Given this list of marker genes Fbxo4, Mkx, Ncor1, Bnip1, Ccdc51 (NCBI Gene Id 66658), Mettl21a, Toe1, Map2k2, Tmem119, Itgb1, Nr2f6, Sgk1, Tiam1, Polr3g, Zfp526, Uck2, Lrrc75a, Afg3l2, Gm1976, Frmd8os, Nemp2, 9930012K11Rik, Asb6, Usp9x, Plod3, Dynlt1-ps1, Tfb2m, Furin, A130014A01Rik, Gabpb1, Mid1ip1, Pgp, Gm15471, Ddt, 6330409D20Rik, Wdr3, Hspa4, Sugct (succinyl-CoA glutarate-CoA transferase), Pacrg, Emc4, Tubb2b, Zfp811, Cnst, E4f1, Copg1, Prss36, Mgat1, Mpv17l2, Prmt9, Igsf8, Snord2, Stra6l, Fv1, Uck1, Katnb1, Vmp1, Stard6, Scrt1, Casp16, Irf1, Rsl24d1, Kank2, Tcea2, Arap1, H6pd (NCBI Gene Id 14379), Cdk13, Naa20, Slc35d1, Ntaq1, Ebag9, E230029C05Rik, Parp16, Brd1, Jmjd6, Havcr2, Ptpmt1, Adprm, Nr2c2, C5ar2, Mir8109, Thap6, Sun2, Gm12500, Lactb2, Mir9-2hg, Efcab2, Cinp, Bmpr1a, Nop16, Ankrd40, Slc38a1, Pcid2, Ppp2r5d, Rock2, Pex5, Nck1, Cenatac, Adamtsl5, Cenpb, Malsu1, Gm15704, Cisd2 (NCBI Gene Id 99732), mt-Nd6, Hmgxb3, Reep5, Pik3cd, Dhdh, Gm18407, Amacr, Wsb2, Ndufs6 (NADH:ubiquinone oxidoreductase core subunit S6), Irak2, Proser1, C1qbp, Tram2, Rbm47, Slc29a2, Tifa, 2610203C22Rik, Gm15510, Rin3, Zbtb7a, Shkbp1, Ilrun, Tmem240, Tnip1 (NCBI Gene Id 57783), Tfcp2, Hdhd5, Rps27l, Pard6a, Traf3, Gm16299, Zfp1006, Rab3il1, Nfe2, Por, Mrpl3, Trak2, Rnft1, Trir, Dgkz, 3110031N09Rik, 2900041M22Rik, Gtf2ird2, Rnf13, Nipa2, Nhlrc3, Gm25703, Ankle1, Zfp444, Acaca, Tgif1, Mbd6, Hlx, Dsn1, Cfap126, Gstm1, Gm35986, Klf4, Spen, Lrmda, Irak4, Vmac, Fam43a, Sipa1l3, Slbp, Hsd17b10, Rnd2, Ndufaf1, Ung, Plekhb1, Mogs, Sgms1, Rps6ka1, Atp6v1g1 (NCBI Gene Id 98834), Gpn3, Trip4, Stn1, Mettl23, Mdfic, Acot8, Map3k8, Baz2a, Rapgef2, A930005H10Rik, Gm16120, 4930595D18Rik, Tmem42, G6pc3, Trpv2 (transient receptor potential cation channel, subfamily V, member 2), Mblac2, Snapc2, Ak4 (NCBI Gene Id 51874), Btf3, Fsd1l, Gga1, Ip6k2, Cdnf, Cd72 (CD72 antigen), Rfc4 (NCBI Gene Id 224052), E2f2, Ddx21, Kpnb1, Gid4, Nr4a3, Pafah1b1, 4930447M23Rik, Ppt1, Trpm8, Bub1, Tektip1 (NCBI Gene Id 432479), Ifitm6, Abhd12, Zc3h14, Rgs18, Elmo2, Hsd17b2, Cltc, Pwwp2b, D130017N08Rik, Rxrb, Cox7a1, Gm4479, Etfa, Dpp9, Mexis, Atp5mj, Slc44a1, 0610043K17Rik, Eif4e, Hrh3, Mcph1, 1700066B17Rik, Tars3, Izumo1, Fntb, Cspp1, Gtpbp4, Gm21992, Dnaja2, Gm14275, Prkn, Hsd17b14, Nhp2, Stk4, Whrn, Ido2, Churc1, Bms1, Frmd4a, Miip, Pparg, Alkbh8, Rptor, Zbtb6, Unc50, Lmna, Orm3, Myo9b, Gm15246, Esrra, Dhrs11, Pdcd4, Lrp11, Znhit1, Nlrp3, Gm27003, Tgfbrap1, Mkrn1, Rbm27, Zdhhc5, 4931422A03Rik, Coq9, Prkar2a, Hsp90aa1, Ipo4, Nfat5, Dyrk2, Diaph3, Mettl2, Opa3, BC048644, Ier3ip1, Vpreb1a, Fam98c, Garin5a, Fbxl13, Nostrin, Arhgap31, Gm16253, Uspl1, Epn1, Aff1, Tdrd3, Cic (NCBI Gene Id 71722), Dbi, St6gal1, Gas7, St8sia5, Pes1, Ptgr2, Pcm1, Cyp2w1, Sdha, Dnaja1, Nln, Uqcrq, Prmt7, 9930014A18Rik, Cd37, Hk3, Ube2q2, Ncor2, Cdk20, Tor3a (torsin family 3, member A), Psma7, Smurf1, Trmt2a, Akt1, Klk1b16, Fblim1, Med1, Eeig1, Sft2d2, Dcaf6, D330041H03Rik, Spag9, Zbtb7b, Gata3, Mib2, Galt, Arid4a, Stk10, Ninj1, Tnip2, Wdr87-ps, Mtag2 (NCBI Gene Id 50994), Syncrip, Epo, Gm43838, 1810019N24Rik, Ulk1, Psd4, Galnt9, Ece1, Cers6, Gm15417, Sec11a, Rcan3, Camta2, Mplkip, 2310061I04Rik, Lilra6, Asf1b, Eno1, Gm23969, Cks1b, Malat1, Src, Ccl9, Degs1, Stk36, Setd5, Hoxa7, Atp5f1b, Slc25a29, Atxn2, mt-Tt, Impact, Ndufb6, Gm29707, Sigmar1, Brms1, Mast3, C3, Upp2, Hsd3b7, Rrm2b, Cytip, Stx16, Josd1, Slc39a7, Gbp11, Patz1 (POZ (BTB) and AT hook containing zinc finger 1), Lrrc42, Hhat, Psma3, Ap5b1, Mtarc2, Arih1, Gm12274, Suds3, Ndufaf4, Hemk1, Fam193a, Zfp101, Hnrnpr, Gm25296, Nfkb2, 4933430I17Rik, Apobec3, Pebp1, Tufm, Eif2s3x, Tomm20, Bach2os, 4930547M16Rik, Rpl12, Junos, Ndufb4, Aldh7a1, Lrsam1, Fdxr, Myo1c, Lipn, Steap3, Tmem65, Ifi207, Rb1cc1, Vamp8, Wdfy3, Smyd3, Hexb, Tradd, Styxl1, Nmbr, Arfrp1, Guf1, Nlrp1b, Kansl1, Mir9-2, Ndufa1, Afg1l, Clec4a1, Pde8a, Gm15133, Ppp2r3d, Tagln2, Gm5617, Atp13a4, Klhdc10, Klhl28, Cul3, Tbc1d9b, Cd28, Tjp2, Txnrd2, Lgals8, Usp3, Exd1, Pld1, Vsir, Gbp10, Ampd2, Pank3, Chp1, Inca1, Pole4, Steap1, Mta2, Mdm4, Phf5a, Tmub1, Dctn5, Mitf, Soat2, Gm16191 (predicted gene 16191), Kif17, Gnaq, Ccdc66, Dph5, Ndel1, Armt1, St3gal3, Gm26654, Eeig2 (EEIG family member 2), Uap1, Mrm1, Stom, Stradb, Homez, Trf, Tma7, Parp10, Vim, Slc7a7, Tmem186, Gm28047, Fasn, Gatad2a, Abca8b (NCBI Gene Id 27404), Cetn4, Ckap5, Tagap, Esyt2, Eif4a2, Cdk5rap1, Tprn, Katnal2, Myef2l, Zfp523, Dnajc4, Kcnab1, Zfyve1, Lrrc8c, Smarcd2, U2surp, Npc1, 4930515B02Rik, E230016M11Rik, Pus7l, Mgst2, Fam3c, Rasl11a, Tbc1d20, Tdrd5, Junb, Hectd2, Slc66a3, Usp46, Vegfb, Phtf2 (NCBI Gene Id 97226), Gmfg, Ccdc88b, Wdfy2, 2210022D18Rik, Fosl2, Oas3, 2310068J16Rik, Zbed4, Eif2b2, Slc11a1, AU019990, Tbc1d25 (NCBI Gene Id 52090), Natd1, Mir8105, Ints6, Zmym2, Relt, Gm20186, Dpy19l1, Ddost, Tmod1, Ranbp1, Atg101, Peli1, Adsl, Alad, Gm16576, Pmm2, Nmnat3, Prrg4, Vegfa, Ggnbp2, Wasf1, Capzb, Neat1, Eef1b2, D430040D24Rik, Dph2, Cnnm3, Gm10244, Ptges, Eif2a, Med23, Ehd1, Bccip, Sdf2l1 (stromal cell-derived factor 2-like 1), Fam90a1b, Pola1, Plscr1, Prkag1, Ptbp1, 2210011K15Rik, Kcnk2, Gm16548, Dmxl2 (NCBI Gene Id 76881), Parvg, 1500002C15Rik, Gm12367, Gpcpd1, Uchl3, Gna13, Ppdpf, Cacnb1, Pex13, mt-Tp, Polr3d, Orai1, Zbtb20, H4c16, Tmem87b, Hcst, Abca1, Sh3bp2, Utp14b, Plk2, Fbxo6, Cd320, Lsm8 (LSM8 homolog, U6 small nuclear RNA associated), Mrpl2, 1700025A08Rik, Uros, Tmco4, Tsc22d1, Ddx50, Ivns1abp, Mcoln1, Erf, A230056P14Rik, Mif4gd, Dmxl1 (Dmx-like 1), Gm10459, Msl2, Ndufa12, 4930563E22Rik, Zhx2, Gm29257, Wdsub1, Luzp1, Pum3, Syngr1, Arid4b, Rasl11b, Mis18a, Ppp1r18, Sema4d, Traf1, Tbc1d4, Mospd3, 2310022B05Rik (NCBI Gene Id 69551), Slc11a2, Rack1, Kremen1, Rnf145, Myo1g (myosin IG), Tmem268, Gpr35, Daam1, Ywhag, Alkbh3os1 (alkB homolog 3, opposite strand 1), Ecsit, A930018P22Rik, Uqcc6, mt-Tv (NCBI Gene Id 17745), Mrps33, Rrm2, Mad1l1, Gm10766, Asb15, Fdft1, Mrps18c, Ppfia3, Pex11a, Foxj2, Isy1, Cox5b, Bbs12, Nudt18, Hdhd3, Fut8, D5Ertd579e (NCBI Gene Id 77811), Prkch, Srp68, Tcerg1, AI597479, Smagp, Bloc1s1, Gm26084, Myadml2, Zfp770, Snai3, Dmwd, Tas1r1, Stx11 (NCBI Gene Id 74732), Mx2, Tpcn2, Rps6kc1, Hes6, Sco1, Nol9, Ilvbl, Ubxn2a (NCBI Gene Id 217379), Snrk, Rad21, Dhrs3, Il12b, Zfpm1, Ptges2 (prostaglandin E synthase 2), Gm6899, Tmem229b, Pyroxd1, Tmem135, Phldb1, Dis3, Rps5, Dip2c, Wdr83, Il16, Lhx1 (LIM homeobox protein 1), 4732491K20Rik, Slc25a10, Gsap, Tnfaip2, Myo6, Fkbp15, Eml2, Osgin1, Ctu1, Eva1c, Gm13431, Bnip3, Agpat4, Znrf1, Hspa1l, Armc10, Cycs, 6720482G16Rik, Gm7285, Coq7, 1700047G03Rik, Yif1b, Commd5, Icam1, F10, Trp53inp2, Ttc7b, Ado, Mir207, Mrpl1, Mad2l2, Sumo3, Vav3, Zmym5, Hycc2, 3110009E18Rik, Rgs19, Cep70, Hnrnpu, Chic2, Usp37, 4930432B10Rik, Zfp706, Ndufc1, H2az1, Lbp, Pkdcc, Tbpl1, Ogdh, Pank1, Smad7, Spata1, Hmgb1, Gm4430, Gm4890, Gm16433, Sirpa, Gm15567, Syt7, 1600020E01Rik, Slc49a4, Aco2, Gm11205, Coq10b, Hpdl, Rnf25, Cd164, Pcgf5, Med28, Nr3c1, Fkbp5, Cdk4, Eny2, Gm6410, Pold4, Sgsm1, Gm15952 (predicted gene 15952), Tceanc, Rhoc, Dbp, Cfap43, Phf13, Nudcd1, Wipf1, Gm16104, Meis3, Naip5, Ska3, Numbl, Cst3, H2-DMa, Plxnd1, Zdhhc7, Wdr4, Mphosph9, Rad23b, Il23a, Hsph1, Mycbp (MYC binding protein), 2310005A03Rik, Psmb10, Nadk, Acsl3, Lexis1, Fos, 2610005L07Rik, Cebpd, Gpr84, Mir5615-1, Emp3, 1500026H17Rik, Gm16279, Agpat5, Ncbp2, Gnb2, Aim2, Ttc21a, Nudcd2, Atf7, B930094E09Rik, n-R5s88, Armc9, Usp48, Ccdc57, Wnt9b, 4930599N24Rik, Maml1, Megf9, Fbxo30, Atrip, Uqcrc1 (ubiquinol-cytochrome c reductase core protein 1), Ippk, Card9, Tpra1, 2300009A05Rik, Jun, Gm5577, Matk, Prkag2, Efcab9, Ttc39a, Hnrnpc, Ogt, Sik3, Apoo, Fndc3a, Zc3hc1, Mpc1, Acox1, Faah, 4930503L19Rik, Il6, Ap5s1, Ikbke, Mon1b, Shc1, Pfkp, Cyth1, Ggnbp1, Map3k4, Repin1, Limk2, Cntd1, mt-Te, 6430710C18Rik, H1f4, Gdf9, Mpc2, Ifrd1, mt-Rnr2, Ciapin1, 4930477E14Rik, Adcy7, Desi1, 2310044K18Rik, Ndufa3, Hk1os, Tnk2, Dnttip2, Gatad1, Stk11, Sdhaf2, Shb, Gm15473, Cisd3, Nucb1, Gm20492, Gm9530, Npas2, Fcrl1, Sestd1, Gm4799, Elovl6, Gins1, Scd2, Wdr55, Gt(ROSA)26Sor, Tnfaip3, Bmt2, Srcin1, Lrrc56, Tob2, Pus10, Mrpl22, Nr2c1, Plpp1, Rnft2, Mmp27, Acsl1, Bcl3, Hspbap1, Calm3, BC049715, Eif1ad, Aebp2, Lcp1, Igsf11, Pafah1b2, Hspa1a, Plcb2, Rbm43, Rev1, Mrpl15 (NCBI Gene Id 27395), Sh2d3c, Selenoi, Pxn, Serp1, Slc2a6, Qdpr, Srebf1, Setd1a, Ppm1g, Gm11457, Acvr1, Psen2, Palb2, Faap100, Dcun1d1, Jpt2, Rmnd1, Mrps18a, Rreb1, Sdf2, Des, 5330439K02Rik, Rragc, Mfn1, Dhrs7, Cmas, Gm11292, Dhx8, Zzef1, Letmd1, Eed, Tfeb, Prss46, Birc3, Dad1 (defender against cell death 1), H4c11, Uba52, Cenpq, Kif18b, Snhg5, Gm26885, Tsen54, Cetn1, Capns1, Senp1, Klhl35, Wee1 (WEE 1 homolog 1 (S. pombe)), Cdk14, Hmmr, Mir330, Kmt2c, Thbs4, Cd82, Kmt5c, Prmt5, Marchf5, Atxn7l3, 2310074N15Rik, Mir8098, Lrrc49, Rasl10a, Mfn2, Mmgt2, Susd1, Gm24595, Ptbp3, Gm6283, Gm7008, Lst1, Zgpat (zinc finger, CCCH-type with G patch domain), Smarcc2 (NCBI Gene Id 68094), Etfbkmt, 4930438A08Rik, Rnf113a1, Gm10138, Synj2, Nacc2, Comt, Lzic, Pkn3, A430093F15Rik, 2310001K24Rik, Nme1, 4930509H03Rik, Ogfr, Mafg, Rbm14, Llgl1, Gm14399, Ubl3, Fstl1, Il13ra1, Inpp4b, Rchy1, Ssbp2, C230057A21Rik, Ppt2, Atat1, 3110056K07Rik, Wdr93, Tbc1d5, Gadd45a, Helq, Hccs (holocytochrome c synthetase), Rmnd5a, Nxf1, Zscan26, Ndufa5, Azin1 (NCBI Gene Id 73525), Ufd1, Mrpl16 (NCBI Gene Id 94063), Vps26a, Mdh2, Ncoa2, Marveld1, Ccdc127, Gm42745, Mir1956, Lfng, Dnaja3, Acox3, Gm33366, Pex2, Cdc40, Ap1g2, Tmem260, Tmem169, Zdhhc14, Gm16046, Lipe, Slc16a6, Rdh5, Klc4, Mrpl19, Afg2a, Mpg, Wbp11, Oxct1as, Mtpap, Mfsd6, Mmp17, Kif2a, Nrbf2, Ssbp3, Wdr83os, Tmtc3, Itga4, Gm37336, Cyb5r4, Cebpg, Tmem273, Pcbp1, Kif1c, Sat1, Caskin2, Spc24 (SPC24, NDC80 kinetochore complex component, homolog (S. cerevisiae)), Fancg, Mrpl50, Gm26901, Gm12542 (predicted gene 12542), Tmem43, Polr2a, Sptlc2, Mrpl57, Pgk1, Hspb7, Gm26626, Mir7043, Aig1, Alkbh7, Amz1, Gm12502, 2610037D02Rik, Ube2e2, Aldh8a1, 8030453O22Rik, Rnf151, Fam13a, Slc25a35, Rcor2, Nek2, Med26, Pias3, Stard7, Rbm15, Rnmt, Slc15a3, Arsg, Hdhd2, Mtmr2, Emc10, Lpcat3 (lysophosphatidylcholine acyltransferase 3), Ublcp1, Stat3, Hras, Fgd4, Spata6l, Sh2b1, Rpl24, Gm7461, Dedd, Mir1938, Mfsd3, Arid2, Taf15, Pdss1, Atox1, Ptprv, Lrpap1, Dedd2, Cpeb3, Xylt1, 8430429K09Rik, Gm25637, Rpl7a, Wdr36, Atp10d, Med31, Stat5b, 9530052E02Rik, Gorasp1, Colec12, Acsl4, Eps15, Pabpc1, Mir1931, Cd93, Atxn7, Ccne1, here is a description of the gene set: Genes containing one or more binding sites for (Nr1h2) in their promoter regions (TSS -1000,+100 bp) as identified by GTRD version 20.06 ChIP-seq harmonization. Mouse Gene Set: NR1H2_TARGET_GENES from publication Yevshin I, Sharipov R, Kolmykov S, Kondrakhin Y, Kolpakov F (PMID 30445619) species: Mus musculus